Given this list of marker genes HMGB2, CENPE, CDCA8, KIF11, MCM5, SMC4, MCM6, MCM7, SMC2, MCM2, ECT2, KIF18A, NDC80, BUB1, CDC25C, CCNE2, MCM4, FEN1, CCNA2, KIF20A, NEK2, MCM3, here is a description of the gene set: studied in species Homo sapiens RB1 target genes involved in cell cycle regulation: genes down-regulated by doxorubicin only in cells expressing RB1. Human Gene Set: EGUCHI_CELL_CYCLE_RB1_TARGETS As alterations in retinoblastoma (RB)/E2F pathway are commonly found in human cancers, the molecular mechanism underlying cell cycle deregulation caused by the mutations in the RB/E2F pathway needs to be investigated extensively. Compared with good understanding of RB/E2F functions in G1-S cell cycle progression, it is not fully understood how an abrogated RB pathway affects the G2-M phase of the cell cycle. Here, we report that disruption of RB accelerated G2-M progression in the presence of DNA damage by elevating the expression of a set of mitotic regulatory genes. We generated RB(+)- and (-)-matched cells using short hairpin RNA. In the RB(-) cells, the G2/M checkpoint mediated by a DNA-damaging agent was over-ridden. With microarray analysis, we found that the expression of key G2-M regulatory genes was upregulated in RB(-) cells. In particular, we demonstrated that the proto-oncogene ECT2 was directly regulated by E2Fs. Furthermore, suppression of ECT2 expression by small interfering RNA in RB(-) cells resulted in cytokinesis arrest, suggesting that RB(-) cells lack the regulation of E2F-mediated cytokinesis. These results indicate that aberrant ECT2 expression, observed in various human tumors, could be the direct result of RB/E2F pathway deficiency, thereby contributing to cell division in cancers. from publication Eguchi T, Takaki T, Itadani H, Kotani H (PMID 16862181)